Given this list of marker genes Tex15, Mbd1, Mov10l1, Ehmt1, Hdac1, Mbd2, Baz2a, Smarca5, Spocd1, Trim28, Setdb1, Dnmt3a, Kmt2b, Dnmt1, Ezh2, Mbd3l1 (methyl-CpG binding domain protein 3-like 1), Piwil4, Fkbp6, Gm38999, Hells, Piwil2, Tdrd1, Bend3, Mbd3l2, Mbd3, Ppm1d, Bmi1, Ctcf, Ddx4, Ehmt2, Atf7ip, Dnmt3l, Kmt2a (lysine (K)-specific methyltransferase 2A), Dnmt3b, Spin1, Mael, Tdrd9, Tdrd12, Tdrd5, here is a description of the gene set: species: Mus musculus Mouse Gene Set: GOBP_DNA_METHYLATION_DEPENDENT_CONSTITUTIVE_HETEROCHROMATIN_FORMATION Formation of constitutive heterochromatin by a pathway that includes methylation of genomic DNA such as CpG islands.